The following is a description of a gene set: The directed movement of basic amino acids from one side of a membrane to the other. species: Mus musculus Mouse Gene Set: GOBP_BASIC_AMINO_ACID_TRANSMEMBRANE_TRANSPORT, and this is the list of marker genes: Slc25a29, Slc15a4, Slc7a2, Slc7a6 (NCBI Gene Id 330836), Slc38a9 (solute carrier family 38, member 9), Slc47a1, Slc7a1, Slc7a3, Cln3, Slc38a4, Slc7a7, Slc25a15, Slc11a1, Slc7a9, Slc22a2, Slc66a1, Slc25a2